The following is a description of a gene set: Mouse Gene Set: MIR_666_3P Genes predicted to be targets of miRBase v22 microRNA mmu_miR_666_3p in miRDB v6.0 with MirTarget v4 prediction scores > 80 (high confidence targets). from publication Chen Y, Wang X (PMID 31504780) studied in species Mus musculus, and this is the list of marker genes: Bicd2, Vsnl1, Crppa, Dusp6, B3galt5, Prom2, Knstrn, Nufip2, Smad2, Cop1, Mlst8, Dner, Ip6k3, Gtf2h1, Txndc17, Mecp2, Taco1, Pip5kl1, Trpd52l3, Tmcc1, Btbd3, Vhl, Dcaf17, Cacna1d, Dclre1c, Sos1, Cyp3a25, Pla2g12a, Pcsk6, Cemip2, Peli2, Dnajc18, Serpinb6b, Kcne4, Cyb561, Nkain1, Zfand6, Sgpl1, Rslcan18, Itk, Ikbkb, Tmem33, Gpbp1 (NCBI Gene Id 73274), Cyp3a59, Celf2, Slu7, Paip2, Fam210a, Myh7b, Ptges, Wapl, Arhgef7, Khdrbs1, Nnt, Creb5, Tjp1, Wnk1, Fem1b, Serpina3n, Itgb1bp1, Zic3, Gjc2, Dicer1, G3bp2, Ecm2, Mllt1, Eif4b, Dlst, Tnfrsf25, Ube2h, Lpin1, Ptpn2, Il1r1, Elmod2, Sox2, Kcnt1, Ybx1, Myo3b, Gpx3, Irf3, Rnf24, Smg7, Ralgps1, Timd4, Serpina3f, Mfsd4b5, Epha4, Kpna4, Seh1l, Slc35b2 (solute carrier family 35, member B2), Rbm4b, Brix1, Fam83d, Abcd2, Pdcd11, Prpf4b, Nat8l, Hspa12a, Enc1, Pde7a, Itih1, Unc80, Dnajc1, Myt1l, Pkd1, Satb2, Krtap7-1, Ccser2, Zfp354a, Lgalsl, Ubl3